The following is a description of a gene set: Human Gene Set: GSE9988_ANTI_TREM1_VS_ANTI_TREM1_AND_LPS_MONOCYTE_UP Genes up-regulated in comparison of monocytes treated with anti-TREM1 versus monocytes treated with anti-TREM1 and 5000 ng/ml LPS (TLR4 agonist). studied in species Homo sapiens from publication Dower K, Ellis DK, Saraf K, Jelinsky SA, Lin LL (PMID 18292579) TREM-1 is an orphan immunoreceptor expressed on monocytes, macrophages, and neutrophils. TREM-1 associates with and signals via the adapter protein DAP12/TYROBP, which contains an immunoreceptor tyrosine-based activation motif (ITAM). TREM-1 activation by receptor cross-linking is pro-inflammatory, and can amplify cellular responses to Toll-like receptor (TLR) ligands such as bacterial lipopolysaccharide (LPS). To investigate the cellular consequences of TREM-1 activation, we have characterized global gene expression changes in human monocytes in response to TREM-1 cross-linking in comparison to and combined with LPS. Both TREM-1 activation and LPS up-regulate chemokines, cytokines, matrix metalloproteases, and PTGS/COX2, consistent with a core inflammatory response. However, other immunomodulatory factors are selectively induced, including SPP1 and CSF1 (i.e., M-CSF) by TREM-1 activation and IL-23 and CSF3 (i.e., G-CSF) by LPS. Additionally, cross-talk between TREM-1 activation and LPS occurs on multiple levels. While synergy in GM-CSF protein production is reflected in commensurate mRNA abundance, comparable synergy in IL-1b protein production is not. TREM-1 activation also attenuates the induction of some LPS target genes, including those that encode IL-12 cytokine family subunits. Whereas positive TREM-1 outputs are abolished by the PI3K inhibitor wortmannin, this attenuation is largely PI3K-independent. These experiments provide a detailed analysis of the cellular consequences of TREM-1 activation, and highlight some of the complexity in signal integration between ITAM- and TLR-mediated signaling., and this is the list of marker genes: CAMKK1, ZNF134, STK24, USP22, CBL, CLTA, SLC8B1, PNP, AP1M1, SERTAD1, OLIG2, CNIH1, MAPKAPK3, SP100, AMD1, ZNF503, KIAA0232, TXNIP, FBXO45, TGFBR1, PTPN6, ALDOA, TMEM70, FUOM, VRK3, UBE2D3, G3BP2, LAPTM4A, CCDC97, PPIF, CNBP, ARHGAP30, RARA, CXCL16, CLIC1, KLHL26, ZNF511, USP3, RGS19, LY9, PLEKHM1, COASY, TSPAN17, MAP1S, S100A2, PLEKHO1, MYL6, OGFR, ARRB2, MNT, TMEM121B, SCARB2, CD180, HM13, POLR3C, CD300LB, NDUFB2, PLEKHO2, SH3BP5, CXXC5, OLIG1, PSMD7, FEM1B, KDM4A (NCBI Gene Id 9682), RNF168 (NCBI Gene Id 165918), APOBR, TLR1, NRBP1, DOK1, FARP1, ARF5, CNEP1R1, TWF2, GNB2, SNX12, PI4K2A, PURA (purine rich element binding protein A), LINC00900, RNF7 (NCBI Gene Id 9616), ARPC5L, CDV3, MKRN1, GABARAP, MIGA2, ATXN7L3, ISCA2, PSD4, DOK2, CYTIP, CYB561D1, CYTH4, FABP5, RALA, WDR82, COPS9, TMEM9B, RREB1 (ras responsive element binding protein 1), NUS1 (NCBI Gene Id 116150), SERTAD3, CTDSP1, NFIC, PPP1CA, ARL11 (NCBI Gene Id 115761), ELOVL1, TM2D2, TLE3, DNASE1L1, HNRNPA0, MED28, MCOLN1, NRBF2, RNF41, CENPBD1P, CHSY1, EIF4EBP2, BCKDK, BLOC1S2, PRELID1, PHC2, PCBP1, TSR2, MIEF1, PRMT6, TNFRSF1A, HOMER3, MAP7D1, NELFB, TMA7, BLOC1S3, MED8, BCAP31, REST, CCR1, BFAR, PAFAH1B2, FASTKD2, ZNF35, CSNK1D, TMEM203 (NCBI Gene Id 94107), LASP1, CAP1, PRR13, SKP1, PRKAG2 (protein kinase AMP-activated non-catalytic subunit gamma 2), DUSP14, PHF13, RING1, ENO1, JMJD8, EOLA1, ZYX, KLF13, YY1, UBQLN2, PSMA7, ACTB, ZCCHC2, IFI30, MBD4, DYNLL1, MRFAP1, LINC01010, RPL27, SLC37A2, SDS, FRAT1, CMTM3, ARID5A, BCDIN3D, ORAI3, RAP2B, DDX6, SUMO2, CAPRIN1, FRAT2, USP10, ST6GALNAC6, ARL6IP1, PHF23, HAVCR2, LRRC25, YWHAG, VPS35, SNAPIN, TBC1D2 (TBC1 domain family member 2), CD2BP2, NTAN1, PPP4C, GGA2, PIK3CG (phosphatidylinositol-4,5-bisphosphate 3-kinase catalytic subunit gamma), DHRS9, FBXO7, ARRDC2, FTH1, PHAF1, KLHL20, FKBP15 (FKBP prolyl isomerase family member 15), CKAP4, PSMG2